The following is a description of a gene set: Human Gene Set: GOMF_ALPHA_N_ACETYLGALACTOSAMINIDE_ALPHA_2_6_SIALYLTRANSFERASE_ACTIVITY Catalysis of the reaction: CMP-N-acetylneuraminate + glycano-(1->3)-(N-acetyl-alpha-D-galactosaminyl)-glycoprotein = CMP + glycano--(N-acetyl-D-galactosaminyl)-glycoprotein. studied in species Homo sapiens, and this is the list of marker genes: ST6GALNAC6, ST6GALNAC4, ST6GALNAC3, ST6GALNAC5, ST6GALNAC1, ST6GALNAC2